The following is a description of a gene set: part of: Nuclear events mediated by NFE2L2 This event has been computationally inferred from an event that has been demonstrated in another species.<p>The inference is based on the homology mapping from PANTHER. Briefly, reactions for which all involved PhysicalEntities (in input, output and catalyst) have a mapped orthologue/paralogue (for complexes at least 75% of components must have a mapping) are inferred to the other species. electronically inferred by orthology from the curated human pathway Reactome Pathway: GSK3B and BTRC:CUL1-mediated-degradation of NFE2L2 species: Mus musculus, and this is the list of marker genes: Psmb5, Psma6, Psmd7, Psmc3, Psmd13, Psmc4, Psmc2, Psmb6, Ubb, Psmc6, Psma3, Cul1, Psma1, Psma2, Psma4, Psma5, Psmd6, Psmb7, Psma7, Psmb4, Rps27a, Psmc5, Psmc1, Psmd12, Psmd1